The following is a description of a gene set: mouse primary BMDCs were stimulated with tlr ligands and gene expression changes were profiled on Affymetrix arrays from publication Amit I, Garber M, Chevrier N, Leite AP, Donner Y, Eisenhaure T, Guttman M, Grenier JK, Li W, Zuk O, Schubert LA, Birditt B, Shay T, Goren A, Zhang X, Smith Z, Deering R, McDonald RC, Cabili M, Bernstein BE, Rinn JL, Meissner A, Root DE, Hacohen N, Regev A (PMID 19729616) Genes up-regulated in comparison of dendritic cells (DC) stimulated with LPS (TLR4 agonist) at 1 h versus DC cells stimulated with CpG DNA (TLR9 agonist) at 1 h. studied in species Homo sapiens Human Gene Set: GSE17721_LPS_VS_CPG_1H_BMDC_UP, and this is the list of marker genes: FBXO9, PRPF19, COX19, CHL1, VPS45, SRRD, SCAND1, GMPPB, RPL3, GPATCH1, FIZ1, PYROXD1, CD151, ENTPD5, TARS2, ROM1, APRT, MRPL10, FANCE, RPS16, NAAA, WDR43, BTG3, PPP1R21, CENPQ, TMEM33, TRIB1, RPLP1, CCNH, ARCN1, PROS1, BRWD3, COPS6, IL12RB2, DFFB, DPH2, KCNK1, DYNLL1, GCSH, DHX15, CCL7, FSTL1, TMEM214, LYPD1, CSE1L, THOP1, MOSPD2, BAG1, PGM2, RTKN, CSTF1, STX3, FIG4, TRAP1, MRC1, REPIN1, DIMT1, CEP19, EMC8, ADGRA3, NSG2, HNRNPUL1, ALG9, OGFOD2, PDCD2, GOLGA7, FKBP4, LZTR1, TNK1, TRAM1, MANBAL, AFG1L, SPIN4, SLC39A7, RHOH, MRPS16, CHCHD3, PHAX, CDC6, PRKCE, CDK4, PDF, SEC23B, ZBTB1, LCLAT1, MRPL49, ACSL5, RUSF1, SEMA6C, CCN1, SNAP23, SELENOT, QTRT1, VTA1, HOXA13, ERCC3, PAICS, AKR1B1, COMMD5, STRC, MSR1, CEP152, MED8, TAF5L, LIAS, CAPN5, HDHD3, ALDH1B1, PALS2, PES1, RAB2A, COA3, BLOC1S6, RNF138, TMEM101, VAPA, NFYB, CCR1, HAUS3, NUBP2, PRXL2C, EVI5, CSPP1, ADGRV1, ZFP1, RARS2, QNG1, TMX2, PIP4P2, PITHD1, SOCS7, NFATC2IP, NIF3L1, TRMT2A, TREH, ADIPOR2, EGLN2, FBXL14, TMEM185A, SOCS6, MMACHC, CTNNBIP1, SUGT1, MAPK11, CNIH1, RSL24D1, ABHD18, ABCB7, PTER, BMS1, METTL8, METAP2, GTF3A, RAB23, PTCD3, COX18, ELP2, NT5C, OPN3, MYCBP2, SERP1, ITIH5, MCM5, SP6, TANGO2, CD4, NDC1 (NCBI Gene Id 55706), LPGAT1 (lysophosphatidylglycerol acyltransferase 1), TM6SF1, KCNJ9 (potassium inwardly rectifying channel subfamily J member 9), THOC1, TFAM, PROKR1, MFSD8, JKAMP, PDCL2, TRIP4, TNFSF8, NDUFA9, MLX, C1orf174, LTV1, GARS1, CCNQ, PSPC1, POLI, MRPS31, MRPL34, PTBP2, MAZ, HSPB2, DNPEP, CRLF1, POC5, PLCB4 (NCBI Gene Id 5332), MRPL9, NKIRAS1, NR5A2, EIF5B, NAA10